The following is a description of a gene set: studied in species Homo sapiens Human Gene Set: HP_SYNOSTOSIS_INVOLVING_DIGITS Synostosis involving digits, and this is the list of marker genes: BHLHA9, PTDSS1, SF3B4, BMPR1B, PCNT, PQBP1, TFAP2B, UBAP2L, NOG, NONO, ROR2, CHSY1, IHH, ANAPC1, RECQL4, MAP3K20, GDF5